The following is a description of a gene set: Human Gene Set: GOBP_DEOXYRIBONUCLEOSIDE_CATABOLIC_PROCESS The chemical reactions and pathways resulting in the breakdown of any one of a family of organic molecules consisting of a purine or pyrimidine base covalently bonded to a sugar deoxyribose (a deoxyribonucleoside). species: Homo sapiens, and this is the list of marker genes: GDA (guanine deaminase), DERA, PNP, ADA, DPYD, XDH